The following is a description of a gene set: Mouse Gene Set: GOBP_PROTEIN_PROCESSING_INVOLVED_IN_PROTEIN_TARGETING_TO_MITOCHONDRION The cleavage of peptide bonds in proteins, usually near the N terminus, contributing to the process of import into the mitochondrion. Several different peptidases mediate cleavage of proteins destined for different mitochondrial compartments. species: Mus musculus, and this is the list of marker genes: Mipep, Pmpcb, Immp2l, Sirt4, Pmpca, Immp1l